The following is a description of a gene set: The chemical reactions and pathways resulting in the breakdown of a leukotriene, a pharmacologically active substance derived from a polyunsaturated fatty acid, such as arachidonic acid. studied in species Homo sapiens Human Gene Set: GOBP_LEUKOTRIENE_CATABOLIC_PROCESS, and this is the list of marker genes: DPEP2, DPEP1, CYP4A11, CYP4F2, CYP4F3, CYP4F12 (cytochrome P450 family 4 subfamily F member 12)